Given this list of marker genes SLC18A1, CYP11A1, DPT, MAGEA9, LY9, GNPAT, ABCC8, RAD51D, OPLAH, ADCY3, TFDP2, MC5R, MFN1, FIG4, CRHR1, SLC22A6, GRIK5, ARL3, ABCB9, IL13, MSH3, HOXD4, GPLD1, NXPE3, PIGB, NTNG2, TMEM11, HTR7, TBX19, SLC2A1, OSBP, IFT27, STK17A, WBP4, NPFF (NCBI Gene Id 8620), SGPL1, FLT1, NR1I2, PRKACA, OPRL1, CFH, SLC46A3, GPR3, KCNA5, KLHL18, SP140, GPR18, TSSK2, TBX5, ZBTB40, AQP7, TRIM24, CASP10, AOC4P, PIGR, SULT2B1, SULT4A1, NEUROD2, PIK3CB, MSL3, ELAVL2, RREB1, BNIP1, DRC3, IVL, PAXIP1, HSD17B3, PAX9, SLC33A1, SLC16A5, GLE1, MDM2, KRT33A, ESR1, KRR1 (KRR1 small subunit processome component homolog), FNTB, WT1, BMP10, ZNF592, CYP2E1, C1orf216, TBC1D22A, NOS2, ATP8B1, PIK3C2A, DTX4, KCNJ6 (potassium inwardly rectifying channel subfamily J member 6), IKBKE, RXRG, EPHB2, POU6F1, RPS6KA5, MSX1, ZBTB22, P2RY10, NFAT5, COX6A2, PVR, ATP6V0A2, ZNF266, ZNF500, NF1, SLC4A3, IL16 (interleukin 16), TMPRSS6, ABO (ABO, alpha 1-3-N-acetylgalactosaminyltransferase and alpha 1-3-galactosyltransferase), KRT86, SIM2, CELA2B, ABCB10, ERCC4, GJB5 (NCBI Gene Id 2709), DNAJC16, PGM3 (phosphoglucomutase 3), IGKV7-3, MLLT10, SLC6A11, here is a description of the gene set: Neighborhood of CASP10 Human Gene Set: MORF_CASP10 Neighborhood of CASP10 caspase 10, apoptosis-related cysteine peptidase in the MORF expression compendium species: Homo sapiens